Given this list of marker genes SPAST, KPNA3, ATL1, TBP, ATXN10, HPDL, ALDH18A1, ZFYVE26, SNCAIP, RTN2, PINK1, ABCD1, ATXN8OS (NCBI Gene Id 6315, ATXN8 opposite strand lncRNA), SACS, ATP1A3, ADH1C, SPG11, LMNB1, PI4KA (NCBI Gene Id 5297), B4GALNT1, EIF2AK1, COQ2, SPART, REEP1, MARS2, TPP1, KIF5A, NR4A2, GBA1, ALMS1, GNB2, MT-TT, LRIG2, ATP13A2, ATXN3, MAPT, UBAP1, HSPD1, WASHC5, NIPA1, TRPV4, CACNA1G (NCBI Gene Id 8913), CPT1C, SPG7, MED27, PNPT1, ATXN2, KCNC3, PLP1, TTPA, FA2H, FXN, SNCA, here is a description of the gene set: Urge incontinence is the strong, sudden need to urinate. Human Gene Set: HP_URINARY_URGENCY Urinary urgency studied in species Homo sapiens